Given this list of marker genes Nrp1, Sema3a, Sema3f, Plxna3, Egr2, Hoxb2, Hoxb1, Plxna4, Hoxa1, Nrp2, here is a description of the gene set: species: Mus musculus Mouse Gene Set: GOBP_FACIAL_NERVE_STRUCTURAL_ORGANIZATION The process that contributes to the act of creating the structural organization of the facial nerve. This process pertains to the physical shaping of a rudimentary structure. This sensory and motor nerve supplies the muscles of facial expression and the expression and taste at the anterior two-thirds of the tongue. The principal branches are the superficial ophthalmic, buccal, palatine and hyomandibular. The main trunk synapses within pterygopalatine ganglion in the parotid gland and this ganglion then gives of nerve branches which supply the lacrimal gland and the mucous secreting glands of the nasal and oral cavities.